The following is a description of a gene set: studied in species Homo sapiens Any process that activates or increases the frequency, rate or extent of chondrocyte differentiation. Human Gene Set: GOBP_POSITIVE_REGULATION_OF_CHONDROCYTE_DIFFERENTIATION, and this is the list of marker genes: GLI3, SOX5, PRKG2, POR, SMAD7, BMPR1B, MUSTN1, LOXL2, SOX6, RUNX2, ZBTB16, PKDCC, GDF5, HOXA11, BMP6, SMAD3, FGF18, ZNF219 (zinc finger protein 219), GDF6, ACVRL1, SOX9